The following is a description of a gene set: Human Gene Set: GOBP_LOCOMOTION Self-propelled movement of a cell or organism from one location to another. studied in species Homo sapiens, and this is the list of marker genes: DPEP1, ZP3, DAG1, SPINT2, LEF1, PLCG2, SPAG9, PTPN1, VEGFC, VSIR, SCN1B, SLAMF8, RTN4, ARID4A, TRPM2, SOD2, HDAC2, NRG1, FAM83H, EFNA1, MIA3, LGALS3, SEMA4C, CKLF, GPR183, ANGPT1, CCL23, RALBP1, AGTR2, MIR150, NUS1, CCL11, CCL24, SELP, RHO (NCBI Gene Id 6010), PECAM1 (platelet and endothelial cell adhesion molecule 1), GCNT1, FGF7 (fibroblast growth factor 7), ING1 (NCBI Gene Id 3621), PTPRK, HSPA5 (NCBI Gene Id 3309), MIR135B, CFAP45, SMPD3, CMTM2, CCL28, SNAI1, ACTN4, IL34, ROBO2, CCL5, FLRT3, SFRP1, XG, LGMN, CDH11, MIR640, AQP1, LBP, EGFR, OR1D2, TNF, CXCL8, ONECUT1 (NCBI Gene Id 3175), SDC4, ITGAX, NTRK3, FLRT2, RICTOR, GPNMB, MTOR, MIR132, PROK2, ELP6, RYK, PHPT1, ZEB2, CYP19A1, IGSF10, STARD13, SRGAP2, AFDN, TRIP6, CCR7 (C-C motif chemokine receptor 7), IL17RC, ABHD2, SMOC2 (SPARC related modular calcium binding 2), MIR93, ARRDC3, TIRAP, SEMA5A, LRRK2, ASCL2, PIK3CG (phosphatidylinositol-4,5-bisphosphate 3-kinase catalytic subunit gamma), ADAM8, GNRH1, SRCIN1, CDKN1B, GNB3, PLA2G1B, SH3RF2, TMSB15C, PLXNB2, BMPER, CUL5, GLIPR2, ADGRG3, VPS35, PLVAP, SIN3B, TNC, TNXB, CTNNA1, MAP2K5, LRCH1, TACR2, ECSCR, IDH2, FUT7, PIK3C2A, MKKS, AP1AR, PTPRT, MIR16-1, CCL17, CCL27, CXCL5, HAS1, GLUL, RECK, SCRIB, ROBO3, ANXA1, NBL1, GLI1, PRKCE, DOCK8, IL27RA, MIR27B, SCRT1, MIR146A, TIE1 (tyrosine kinase with immunoglobulin like and EGF like domains 1), IRGC, ITGA3, CCDC125, CD40, ALOX15B, TNFSF11 (NCBI Gene Id 8600), VEGFA, DEFB114, CCRL2, ITGA4, TACSTD2 (tumor associated calcium signal transducer 2), F2R, SEMA4G, EGR3, IL1B, TNFSF18, MIR137, MYD88, SERPINB1, C3AR1, PTPRU, MIR205, NUP85, CAVIN1, CD99, CREB1, CCL3, MIF, MIR1298, PTPRJ, EDN2, ALOX5, P2RX4, DAPK2 (death associated protein kinase 2), CXCL2, FES, TACR3, FAM107A, LECT2, FGFR1, MIR519D, EPPIN, PDGFRA, DOCK5, MIR494, SYNPO2, PATZ1, MDK, CCN3, IL24, STK39, ADA, HTR1D, ROBO1, WNT4, CNN2, CMTM8, IGFBP3, BEX4, TWIST1, IL12A, SRGAP2C (SLIT-ROBO Rho GTPase activating protein 2C), KLF4, STMN1, KIF20B, AJUBA, S100A11, PDCD6, GRN, FBXO5, MIR487B, APPL1 (NCBI Gene Id 26060), SEMA6A, PAK1, DEFB109B, ACKR2, HSPB1, ELP3, CXCL12, ENPP2, PTPN23, EMILIN2, RAP2A, MGAT3, NEXN, ARHGEF7, MIR145, RBBP4, TMIGD1, POU4F2, TRPV4, PAX6, NINJ1, MACIR, ARHGEF16, EVL, CEMIP, CD69, CITED2, MIR1908, CAPN7, MIR212, VIL1, MSTN, NR4A1, CCDC25, MYLK (NCBI Gene Id 50483), SCAI, ARTN, PDGFC, PLXNA4, DEFB103A, PARVA, SIN3A, XCL1, MIR1-1, JUN, S100A4, MIR29B1, FGF22, BVES, CFAP20 (NCBI Gene Id 29105), TNFSF14, MIR493, MIR362, CHGA, GPLD1, OPN4, IL33, AIRE, PTPRO (NCBI Gene Id 5800), DUOX1, ATP8A1, GPR173, ARRB2, F7, INSM1, WNK1, DPP4 (dipeptidyl peptidase 4), ONECUT2, FERMT2, CCL4L2, RNF20, KRT5, PGAM4, HYAL2, BAG4, PIK3R3, BDKRB1, FGFBP1, MIR133A1, FIGNL2, MIR222 (NCBI Gene Id 407007), STK26, MIRLET7F1, KIF9, JPH3, IQSEC1 (IQ motif and Sec7 domain ArfGEF 1), FUT3, ROBO4, ACVR1, MIR320A, SEMA3B, STAT5A, TYMP, STK4, TGFBR2, LGR6, DUOXA2, SUDS3, SAP130, EDNRB, UNC5D, MIR4500, PTP4A1, TGFBR3, C5, MIR505, CDC42, GCNT2, PDGFD, MYOCD, MADCAM1, JAM2, FGF2, SGK1, MAZ, CYGB, TIAM1, CCL19, MMP14, GNA13, CD200R1, DDT, SULF1, CEACAM1, NCK1, SRF, FERMT3, WDR1, MIR588, SERPINF1, MDM2 (NCBI Gene Id 84825, MDM2 proto-oncogene), DUSP3, AMOTL2 (NCBI Gene Id 51421), SYNJ2BP, RAPGEF2, GCSAM, CXCL16, RGCC, TNN, CXCL17, PTPRM, MIR335, MEF2C, TMEFF2, PPIB, VCL, MIR181B1, VRK1, CGA, SPI1, TBCCD1, SLC12A2, PLPP3, APPL2, PIP5KL1, KANK1, CXCL14, GREM1, MIR218-1, LGALS9, CARMIL2, MIR30A, ADARB1, ADIPOR1, MIR181D, ADRA2A, EPB41L5, SEMA6D, ZNF304, DLC1, CRK, ELP5, SYDE1, PPARG, FUZ, ANXA3, MAPRE2, SBDS, HSPA8, APC, MIR24-1, BBS4, STC1, DLG5, CLDN5, COL1A1, CCL15, ADGRB1, PLEKHG3, IRS2, IGF1, CAV1, CD300A, CCR10, MIR15A (NCBI Gene Id 406948), CALR, ATOH7, NUMB, TPM1 (tropomyosin 1), MIR22, CXCR1, S100A14 (NCBI Gene Id 57402), TMSB10, CEACAM6, NSMF, SFRP2, CCAR1, SCG2, PGF, ETS1, CARD10, GAS6, THBS4, DAB2IP, EPPK1, ARID4B, DNM1L, CD81, CXCR3, JUP, PLXNB3, CIB1, GNAI2, CTTN, PLK2, TAFA4, ACVRL1, SOX14, ITGB2, CASS4, HMGB2, GSK3B, RIGI, MIR210, CMTM3, TGFB1, NPPC (NCBI Gene Id 4880), CCL2, SPRY2, PIKFYVE, NKX6-1, TTLL6, MIR126, MIR329-1, MIR491, NIPBL, FLT1, SEMA7A (NCBI Gene Id 8482), LYN, EPHA7, CCR8, TNFRSF11A, MIR342, CFAP206, MIEN1, CXCL13, MIR133B, BMP4, LRRC15, ARHGAP4, MIR31, ROCK2 (Rho associated coiled-coil containing protein kinase 2), PTK2, TEX101, FLT4, INS (NCBI Gene Id 3630), ATP1A2, DOCK10, TMSB4X, L1CAM, CEP43, NCKAP1L, RHOC, TSC2, FGF20, YTHDF1, IL16, PDE4B, PIK3CD (NCBI Gene Id 5293), IP6K3, MAP2K2, RET, BBS2, TBC1D24, PRKD1, FLNA, MIR200A, UNC5C, PROX1, SFTPD, MIR30C2, PITX2, TRPM4, PF4V1, CD63, CCR4, SRGAP3, FGF9, SELENOK, LAMA3, MIR2355, TPBG, MAPK1, KIF21A, CSF1, MAGI2, PRKD2, RHOG, S100A12, KRT16, TNFRSF18, FOXF1, TNR, JAM3, ENG, PLCG1, SRGAP1, MTA2, MIR149, RAB11A, SEMG1, DDR2, PRKX, AGTR1, RRAS, FADD, CCN1, CTNNA2, PRR5L (NCBI Gene Id 79899), CDH5, IL10, MACO1, TREM1, CREB3, MET, CD300H, APP, LOX, GPI, SPATA13, PLAUR, SLIT1, BST1 (bone marrow stromal cell antigen 1), NTF3, GAS2L2, CXCR6, MIR101-1, DEFB131A, WNT7B, TJP1, CMTM7, AKT1, SUN2, EPHB1, C5AR1 (complement C5a receptor 1), CORO1C (NCBI Gene Id 23603), BBS1, SRP54, CCR6, LDLRAD4, CXCR5, NR2F2 (nuclear receptor subfamily 2 group F member 2), CSF3R, PPM1F, PLP2, SWAP70, RAP2B, CAMK2A, CYP1B1, MTUS1, CTSH, MIRLET7G, FGF17, ARHGAP18, IL6, MIR29C, PLEKHG5, CHRM4, SERPINE1, LTB4R2, RIN3, LAMA1, TBXA2R, PTK2B, EMILIN1, DEFB103B, FOXO4, CERS2 (NCBI Gene Id 63903), ROCK1, FOLR2, XCL2, STK10, CLXN, PREX1, CBLL1, MIRLET7A1, RAB25, PTGDR2, CCL22, SST, DEFA1, RHOB, SAP30L, S1PR1, GPR18, INSR, JAG1, CDH13, ADAM17, RNASE2, MIR34A, CXCR2, MIR152, P2RY12, HDAC6, HDAC7, TGFB2 (NCBI Gene Id 7042), PIN1, ARHGEF2, MALAT1, SPNS2, CD151, NHERF1, BCL6, PDPK1, PIP5K1A, MIR214 (microRNA 214), ANGPTL3, COL3A1, ADAM10, RNASE10, BRMS1, LAMA2, LMNA, MSMP, TGFBR1, GJA1, TCAF2, SSX2IP, HBEGF, WDPCP, BMPR2, HGF, NEFL, F2RL1, MIR543, CXCL10, NFE2L2, HOXB9, WASL, TEK, SEMA3E, MIR92A1, CFL1, GHSR, GADD45A, ITGA2B, CCL7, LDB1, DAPK3, TBR1 (NCBI Gene Id 94313), GPER1, MIR196A1, PLXNA2, SRC, IGSF8, FZD4, MIR200B, ZNF268, DEFB104A, TREM2, CSF1R, CRKL, SPN, MIRLET7B, HMGB1, NAV3, APOA1, EPHA4, SORL1, ADGRG1, LRP1, APOE, WNT5A, ATM, MEGF8, ULK4, CASP8, ARHGEF5, OGT, CSNK2B, NTNG1, KRIT1, PINK1, GDNF, EDN1, RELN, ITGA2, RALA, RRAS2, ATP5F1B, EMP2, LDB2, EPHA1, BMP7 (NCBI Gene Id 655), DPYSL3, PLAA, SMIM22, RREB1, CLASP2, F10, ST3GAL4, MIR665 (NCBI Gene Id 100126315), SEMA3D, ACE, TERT, MIR892B, SOCS7, CCL3L3, MIR711, RUFY3, ANO6, CMKLR1, SIRT1, TET1, MIR221, MIR410, EFNB2, RCAN2, PLET1, NGFR, DNAJA4, WASHC1, TMSB15B, TPPP2, DUSP22, MIR497, PIK3R1 (NCBI Gene Id 5295), MGAT5, FPR1 (NCBI Gene Id 2357), ELANE, MYO1C (myosin IC), SOX9, NTNG2, KLRC4-KLRK1, PPP3CA, BCR, NDRG4, DOCK7, KIF26A, TACR1, VAV1, MIR10B, NEDD9, VEGFB, VASH1, SEMG2, ZNF609, PDGFRB, ZC3H12A, CD9, CHRD, MIR23A, LPAR1, MIR20A (microRNA 20a), MIR185, GCSAML, SHH, MCAM, PTPN2, BRAF, CD47, FGR, SP1, CTSG, MMP3, EP300, PLA2G6, NRP1, PODXL, TAC3, MYCBP2, KIF2A, MIR520D, PKN2, SDCBP, ITGB1BP1, CMTM1, LAMA5, SERPINE2, CADM4, PRKCA, INSL3, PTEN, GPSM3, CCR1, EPHB2, AAMP, RIPOR2, GSX2, DMTN, MIR376C, FERMT1, MIR199A1, DOCK4, PTGER4, FOSL1, PLXNC1, APOD, PF4, CLEC7A, CCL8, DEFB130A, OXSR1, TTBK2, PPIA, SLC25A46, XCR1, NOS3, RHOJ, ACTG1, USP17L2, CD200, BMP2, CAMSAP3, ADTRP, FGF23, C1QTNF8, MIR151A, CCL4, HRG, CLDN3, CAMK1D, BSG (basigin (Ok blood group)), PHLDA2, BMERB1, SMURF2, SCARB1, SPOCK3, TMEM196, FN1, PRKCQ, PRKCD, EZH2, TAC4, CCL18, PLEC, MIR92B, PRKG1, DUSP10, SLIT3, CXCL11, CDH1, KITLG, VAV3, SLAMF1, MIR193A, DEFA4, MAP4K4, MIR590, SMAD7, CCL13, CCBE1, MIR206, GFUS, TNFAIP6, PEAK1, FAT1, MIR140, GRB7, ITGB1 (integrin subunit beta 1), DUSP1 (dual specificity phosphatase 1), JAK2, SEMA3F, NKD1 (NCBI Gene Id 85407), ADAM7, HTN1 (histatin 1), FGF16, CH25H, RAP2C, SMAD3, FPR2, POSTN, GTPBP4, MIR200C, TLR4, GHRL, SNCA, STX4, DNAI3, TMIGD3, SPARC, HAS2, LYVE1, MAPK3, OSBPL8, ITGA5, AGT, WAS, PIP5K1C, CXADR, ADGRE2, MIR551A (microRNA 551a), P4HB, DEFB1, ACTA2, PTPRR, GRIA1, FGF8, PLXNB1, JAML, CYRIB, FGF6, FSHB, MMP2, RACK1, RAC3, ELMO2, MIR638, IL6R, MIR492, RIPOR1, FPR3, IL1R1, KLRK1, DEFB104B, CHRM1, CFAP69, GATA2, MYSM1, SH3BP1, SYK, VEGFD, FUT1, TRADD, RIPK3, ING2, CORT, CARMIL1, FCER1G, AZU1, PLAU, ADAM15, AKAP12, MIR19B1, LAMB1, TRIM32, CCR3, MIR223, PEAK3, ABHD6, CLDN19 (NCBI Gene Id 30063), MIR26A1, PLCB1, MIR15B, AKIRIN1, CHST2, MIR338, PERP, MED23, TCAF1 (TRPM8 channel associated factor 1), MIIP, PLA2G7, CLDN4, WNT5B, CATSPER1, PSEN1, VCAM1, RAC1, RNASE3 (ribonuclease A family member 3), DACH1, ARID2, PDCD10, BMP5, PRDM14, SMO, GPR15LG, PDPN, DOCK1, AIF1, ITGA6, MAP2K3, CD74, DRD1, MMP28, IL17RA, CORO1A, PLXND1, CCL21, EPB41L4B, BMPR1A (NCBI Gene Id 8035), EGF, CCL20, CDK6, NOVA2, AKT3, MAPK15, DOCK2, VTN (vitronectin), IGF1R, SERPIND1, DEFA1B, MIR129-1 (NCBI Gene Id 406917), CXCL6, ARHGAP5, RCAN1, PHACTR1, CXCL3, HRAS, ATP1B2, RPL13A, NODAL, ADIPOQ, ABCC8, HOXA7, NRP2, FUT9, HDAC9, NOG, MIR939, CORO1B, ATP2B4, SLIT2, MIR204, PPP2R3A, XBP1 (NCBI Gene Id 7494), INPP5F, CLN6, PLD1, PKN1, C1QBP, ADGRA2, PIK3C2G, MIR449A, DSCAM, SLURP1, CASR, ADORA3, GDF2, RARRES2, BST2, CXCL9, CX3CR1, ITGA9, DEFB133, CCDC39, RDX, MYCNOS, MEOX2, GDF15, LSP1, MIR483, ITGAV, BIN2, SEMA4B, SEMA3C, NRG3, SCRT2, CCR2, PPARD, NR4A3, TP53INP1, MIR424, DSG3, BCAS3, MIR302C, NTN1, GRIN2C, DEFB110, CXCL1, IFITM1, MPP1, ECM1, MIR224, ABL2, FBXO7, FOXP1 (forkhead box P1), ARPIN, HACE1, BRMS1L, MIR448, IGFBP5, DUOX2, CD99L2, FRMD5, CYSLTR1, TMEM201, CCL16, ARF6, USP14, SRGAP2B, SAA1, ALKBH1, LAMC2, FAM89B, ERBB4, HDAC1, CCR5, BCAR1, KDR, SPOCK2, COL6A1, ACKR3, MIR451A, PTGS2, MIR19A, EDN3, AKT2, PIK3CB, RIN2, MIR885, PFN1, TRIB1, MMP7, CCL1, MOSPD2, PODN, FGF3, MIR503, SEMA4D, FEZF2, ADAM9, ROGDI, WDR62, FGF10, SELE, MSN, OR10J5, MIR182, BCL2, DEFB124, SEMA6C, YTHDF3 (NCBI Gene Id 253943), GBF1, PTPRC (protein tyrosine phosphatase receptor type C), GNA12, BRINP2, ITGB3, THBS1, MINK1, RHOA, SASH1, ABL1, PTN, FAM110C, MEAK7, MAP2K1, LIMCH1, RPS19, MIR27A, PTAFR, ARSB, TAC1, ATOH8, CCR9, FGF5, FGF21 (NCBI Gene Id 26291), S100A9, CYP7B1, MMRN1, MITF, FOXO3, FGF4, CLIC4, PPBP, WNT3, EPHA2, ACKR4 (atypical chemokine receptor 4), SYNE2, RABGEF1, ZNF703, CXCR4, ANOS1, TMSB15A, MIR3173, ADAMTS1, NKX2-1, MIR208A, DEFB4A, SSH1, SEMA5B, SAP30, LCN2, CDK5, GSTP1 (glutathione S-transferase pi 1), SINHCAF, IL23A, SEMA4A, LRIG2, MCC, TMEM102, HCRTR2, MIR296, RCC2, IQCF1, DAB2, MIR495, EFNA5, ARHGEF39, S100A8, STAP1, TBX5, SP100, CCL14, MAP3K7, GAB1, CCN4, SPHK1, MIR143, ZMYND8, FGF1, EMC10, TWIST2, MIR130A, PPP3CB, FUT4, HIF1A, MIR128-1, PLG, FFAR2, RHOD, DAAM2, F3, SERPINB3, ANGPT4, MCU, DRD2, MIR1290, CPNE3, PRCP, CAMK2B, BMP10, CSF2, LMO4, TUBB2B, ACVR1C, LAMA4, KIT, STK24, PYCARD, S100A7, PRAG1, LYST, MIR181A2, MIR379, IL4, THY1, FER, CHST4, FBN2, ANGPT2, DDRGK1, SLC26A5, WNT3A, DEFB130B, APOH, JCAD, PHLDB2, PFN2, UBE2I, MIR361, C8orf44-SGK3, ICAM1, CCL26, RNF7, C5AR2, DCN, GPR37, GATA3, APELA, WNT7A, ITGA1, SGK3, NOTCH1, ADAMTS9 (ADAM metallopeptidase with thrombospondin type 1 motif 9), NISCH, SVBP, MCTP1, MMP9, PDGFB, MIR9-1, SPRED1, COLEC10, PLGRKT, MAPK14, AMOTL1, NF1, NF2, TMSB4Y, ROR2, STX3, AGER, SHTN1, SLK, RAB13, CRIPTO, MIR499A, PDGFA, PARD6B, HDAC5, SEMA3G, CX3CL1, FGF18, CMTM5, NR2E1 (nuclear receptor subfamily 2 group E member 1), TIMP1 (NCBI Gene Id 7076), FOXC2, MIR21, CCL25, TALAM1, SNAI2, RFFL, AMOT, CALCA, ACVR1B, PTPRG, ATP5F1A, MMRN2, NEXMIF, AGO2, MIR29A (microRNA 29a), RAC2, SRPX2, RNF41, CLN3, DLL4, ARHGDIB, STAT3, TNFRSF14, ZNF580, HSD3B7, GRIN2A, CNR2, MIR138-1, KIF14, RBBP7, FGF19, SUCNR1, MACF1, PADI2, ABCC1, SEMA4F, MARVELD3, SEMA6B, MIR10A, FBLN1, IFNG (NCBI Gene Id 3458), SLC8B1, MYOC (myocilin), PLXNA3, HMOX1, SEMA3A, CLASP1, MECP2, PLXNA1, MICOS10-NBL1, ADORA1, CLDN1, MYADM, ABI3